Given this list of marker genes AQP8, SLC26A6, SLC7A11, SLC11A2, ACE2, SLC6A18, MTTP, AMN, SLC17A3, AQP1, CYBRD1, TRPM6, CD36, FOLR1, CLTRN (collectrin, amino acid transport regulator), SLC5A6, SLC26A3, SLC20A2, DRD5, CUBN, SLC22A5, SLC26A4, ABCG2, KCNK1, ABCB1, GNA13, MFSD10, SHANK2, NHERF1, SLC46A1, SLC34A3, SLC17A4, SLC28A3, SLC28A1, PLB1, GNA12, SLC34A1, CA4, SLC19A1, PDZK1, SLC22A12, SLC3A1, SLC27A4, SLC9A3, CDHR5, SLC7A9 (NCBI Gene Id 1461), B4GALT1, SLC34A2, CDHR2, SLC5A1, SLC6A19, PEX19, LIMA1, SLC28A2, ITLN1, LRP2, HSP90AA1, PLD2, ATP6V0A4, here is a description of the gene set: species: Homo sapiens Human Gene Set: GOCC_BRUSH_BORDER_MEMBRANE The portion of the plasma membrane surrounding the brush border.